Given this list of marker genes GOLGA2, TMED5, GOLPH3, TRIP11, MYO18A, FHDC1, PRMT5, OPTN, VAMP4, GORASP1, GCC2, here is a description of the gene set: species: Homo sapiens Human Gene Set: GOBP_GOLGI_RIBBON_FORMATION The formation of a continuous ribbon of interconnected Golgi stacks of flat cisternae.